The following is a description of a gene set: Mouse genes annotated to HALLMARK_APICAL_JUNCTION based on orthology mappings provided by the Alliance Genome Consortium species: Mus musculus Mouse Gene Set: HALLMARK_APICAL_JUNCTION from publication Howe DG, Blake JA, Bradford YM, Bult CJ, Calvi BR, Engel SR, Kadin JA, Kaufman TC, Kishore R, Laulederkind SJF, Lewis SE, Moxon SAT, Richardson JE, Smith C (PMID 30224793), and this is the list of marker genes: Ldlrap1, Tro, Nrxn2, Col9a1 (NCBI Gene Id 12839), Layn, Dhx16, Cdh4, Col17a1, Kcnh2, Ppp2r2c, B4galt1, Akt2, Itga3, Pcdh1 (protocadherin 1), Cx3cl1, Mapk11, Myh9, Tnfrsf11b, Arpc2, Rhof, Msn, Syk, Cldn5, Nectin3, Fyb1, Dmp1, Myh10, Icam1, Tubg1, Madcam1, Itgb4, Shc1, Slc30a3, Tspan4, Vcam1, Nherf4 (NCBI Gene Id 170761), Zyx, Pecam1, Dsc3, Nexn, Cdh3, Map4k2 (NCBI Gene Id 26412), Adra1b, Itgb1, Gnai2, Calb2, Mdk, Shroom2, Tgfbi (NCBI Gene Id 21810), Cdh11, Cd274, Pals1, Fscn1, Hras, Slit2, Atp1a3, Actc1, Adamts5, Lama3 (laminin, alpha 3), Pik3r3, Pbx2, Baiap2 (brain-specific angiogenesis inhibitor 1-associated protein 2), Amigo1, Cldn4, Sympk, Acta1, Ptprc, Sirpa, Nrtn, Mpzl1, Ctnna1, Negr1, Tsc1, Hadh, Cercam, Tjp1, Gnai1, Nf1, Mmp2, Rras, Crb3, Mapk13, Grb7, Vwf, Actb, Plcg1, Insig1, Jup, Itga2, Icam2, Cldn11, Cldn19, Alox8, Jam3, Pten, Nectin2, Exoc4, Icam5, Vcan, Pkd1, Nectin1, Vav2, Sgce (sarcoglycan, epsilon), Cd209b, Ptk2, Lima1, Gtf2f1, Cdk8, Cntn1, Actg1, Cnn2, Bmp1, Myl12b, Pard6g, Cldn7, Gamt, Actn4, Cldn6, Myl9, Parva, Lamc2, Crat, Col16a1, Nrap, Adam15, Adam9, Nlgn2, Cdh6, Cdh8, Icam4, Thy1, Epb41l2, Dlg1, Lamb3 (NCBI Gene Id 16780), Cd276, Cap1, Stx4a, Arhgef6, Cldn14, Actn3, Actn2, Nf2, Wnk4, Cd34, Cdh1, Rac2, Rasa1, Vcl, Rsu1, Itga10, Itga9, Skap2, Egfr, Src, Sorbs3, Cadm2, Cdsn, Cldn9, Evl, Wasl, Tial1, Akt3, Flnc, Actn1, Mapk14, Adam23, Amh, Ctnnd1, Nlgn3, Krt31, Cdh15, Cd86, Irs1, Amigo2, Cldn15, Sdc3, Mvd (mevalonate (diphospho) decarboxylase), Speg, Cldn18, Map3k20, Actg2, Thbs3, Dsc1, Traf1, Ikbkg, Pfn1, Taok2, Mpzl2, Ywhah, Mmp9 (NCBI Gene Id 99431), Tmem8b, Inppl1, Nectin4, Cldn8, Vasp, Nfasc, Cadm3, Pik3cb, Fbn1